The following is a description of a gene set: species: Mus musculus Any collagen binding that occurs as part of cell-matrix adhesion. Mouse Gene Set: GOMF_COLLAGEN_BINDING_INVOLVED_IN_CELL_MATRIX_ADHESION, and this is the list of marker genes: Itga1 (NCBI Gene Id 320601), Itga2, Itgb1, Itga10, Itga11